Given this list of marker genes Psmd1, Psmd14, Pola2, Cdk4, Skp2, Psma5, Ccna1, Cdkn1b, Cdt1, Prim2, Wee1, Ccne1, Rpa3, Psmd11, Psmd8, Psmc5, Orc6, Mcm8, Cdkn1c, Psmc3, Psmd13, Rpa2, Cables1, Psmb1 (proteasome (prosome, macropain) subunit, beta type 1), Psmd3, Cdc7, Rps27a, Ppp2cb, Mcm2, Ptk6, Ppp2r3d, Psmc4, Cdkn1a, Psmc2, Mcm5, Psmd2, Mcm10, Psmb2 (NCBI Gene Id 27983), Orc4, Akt3, Ppp2ca, Cul1, Psma6, Psma3, Psmd7, Orc2, Psma7, Uba52rt, Ubc, Mcm7, Cdc45, Orc5, Prim1, Mcm4, Pole4, Mcm6, Akt1, Pole3, Psmc1, Ccne2, Uba52, Psmb7, Psma1, Ppp2r1b, Cdc6, Ppp2r1a, Psmb5, Psmb3, Mcm3, Ccnh, Skp1, Gmnn, Psmd6, Pole2, Psmb6, Mnat1, Psmb4, Cdc25a, Pole, Rpa1, Pola1, Cdk2, Ccna2, Akt2, Adrm1, Psma4, Psmc6, Cdk7, Orc3, Ccnd1, Psmd12, Cks1b, Orc1, Ubb (ubiquitin B), Dbf4, Psma2, Rb1, here is a description of the gene set: G1/S Transition Mouse Gene Set: REACTOME_G1_S_TRANSITION species: Mus musculus